The following is a description of a gene set: species: Mus musculus Regulation of TBK1, IKKε (IKBKE)-mediated activation of IRF3, IRF7 Mouse Gene Set: REACTOME_REGULATION_OF_TBK1_IKK_IKBKE_MEDIATED_ACTIVATION_OF_IRF3_IRF7, and this is the list of marker genes: Uba52, Ticam2, Uba52rt, Tlr4, Ubb, Ikbke, Optn, Cd14, Ubc, Ly96, Ticam1, Tank, Tbk1, Rps27a, Traf3